Given this list of marker genes TGFB2, IL4R, TLR7, MIR24-1, PDCD1, MIR200A, MIR203B, MIR21, CD274, TLR4, MIR24-2, TRAF6, CXCL10, MIR138-2 (NCBI Gene Id 406930, microRNA 138-2), MIR203A, MIR138-1, NFKB1, TGFB3, IL4, CD80, NFKB2, MIR155, MIR29A, MIR27A, TGFBR2, CD86, STAT3, TLR8, STAT6, MIR200C, MIR23A, MIR214, IRAK4, CCL5, IL2RB, CCL2, TGFB1, PIAS3, MIRLET7D, SOCS1, MIR146A, MIR212, IL2RA, MIR34A, MIR210, CTLA4, MIR200B, IL2RG, here is a description of the gene set: species: Homo sapiens Interactions between immune cells and microRNAs in tumor microenvironment Human Gene Set: WP_INTERACTIONS_BETWEEN_IMMUNE_CELLS_AND_MICRORNAS_IN_TUMOR_MICROENVIRONMENT